The following is a description of a gene set: species: Homo sapiens Human Gene Set: GOBP_NEGATIVE_REGULATION_OF_CYTOKINESIS Any process that stops, prevents, or reduces the frequency, rate or extent of the division of the cytoplasm of a cell, and its separation into two daughter cells., and this is the list of marker genes: TEX14, E2F7, VPS4A, E2F8, CHMP4C, ZFYVE19, AURKB